Given this list of marker genes Cpb2, Abca12, Mapk13, Gclm, Bad, Th, Foxo3, Abcc8, Stxbp4, Mup11, Slc12a7, Rab11b (RAB11B, member RAS oncogene family), Ccl2, Gpx1, Myt1, Nadk, Unc13b, Cyp7a1, Ptprn, Mpc2, Pla2g6, Agt, Baiap3, Zbed6, Map2k4, Lepr, Ogt, Gck, Lep, Sybu, Igf1r, Aacs, Tgfb1, Gpld1, Rac1, Foxa2, Mir410, Cftr, Raf1, Lrp1, Trem2, Slc9b2, Ccdc186, Rab34, Nr1h4, Lin28a, Sox4, Vcam1, Smad2, Pax6, Casr, Trpm4, Rab11fip2, Prkcb, Ppara, Kcnj11 (potassium inwardly rectifying channel, subfamily J, member 11), Ano1, Mir320, Pde8b (phosphodiesterase 8B), Gprc6a, C1qtnf12, Ins1, Dynll1, Abcg1, Adra2a, Trpm5, Mup1, Pax2, Sirt1, Zbtb20, Slc12a6, Hmgcr (NCBI Gene Id 218474), Gper1, Nptx1 (NCBI Gene Id 18164), Pde1c, Rps6ka2, Zfp36l1, Srf, Endog, Ptprn2 (protein tyrosine phosphatase receptor type N polypeptide 2), Cltrn, Tcf7l2, Jagn1, Tjp1, Mup3, Mir379, Pik3ca, Mir192, Irs2, Ppp3ca, Rab11fip5, Crhr2, Nr1d1, Stx4a, Xbp1, Mir27a, Mlxipl, Rfx6, Ncoa6, Cacna1e, Ppp3cb, Map2k3, Pde3b, Hcfc1, Mup2, Tunar, Camk2n1, Neurod1, Tbc1d1, Oprk1, Icam1, Usf1, Mup4, Osbp, Brsk2, Myh9, Fto, C2cd2l, Prkaa1, Smarca4, Pck1, Fbp1, Mir130a, Tra2b, Hmgn3, Oxct1 (NCBI Gene Id 67041), Ndufaf2, Mir337 (microRNA 337), Hnf1a, Sri (NCBI Gene Id 73025), Keap1, Ern1, Tiam1, Mir369, Mir532, Sin3a, Slc29a1, Nox4, Vsnl1, Pih1d1, Ace, Pck2, Gclc, Gpr27, Sidt2, Crh, Ager, Klf7, Epha5, Kat5, Ghrl, Gpr68, Lrp5, Adcy8, Cdk16, Trpa1, Prkce, Slc2a5, Gpr39, Grk2, Calcrl, Mup5, Prkn, Eny2, Prkaca, Prkca, Ptpmt1, Pde4c, Ang2, Aqp4, Mir200a, Ucp2, Rptor, Apoc3, Gcg, Usf2, Col1a1, Piwil4, Kcnb1, Igf1, Slc26a6, Rack1, Nfkb1, Ppard, Map2k6, Smad3, Cacna1d, Slc2a2, Star, Twnk (twinkle mtDNA helicase), Gas6, Serpinf1, Map4k4, Fkbp1b, Efna5, Selenot, Atg7, Pdx1, Hif1a, Prkaa2, Plcb1, Pim3 (proviral integration site 3), Slc39a14, Adcy5, Kif5b, Smarcb1, Arrb1, Gjb6, Smad4, Rbm4, Birc5, here is a description of the gene set: Any process that results in a change in state or activity of a cell (in terms of movement, secretion, enzyme production, gene expression, etc.) as a result of a carbohydrate stimulus. studied in species Mus musculus Mouse Gene Set: GOBP_CELLULAR_RESPONSE_TO_CARBOHYDRATE_STIMULUS